The following is a description of a gene set: studied in species Mus musculus Mouse Gene Set: GOBP_POSITIVE_REGULATION_OF_PROTEIN_IMPORT_INTO_NUCLEUS Any process that activates or increases the frequency, rate or extent of movement of proteins from the cytoplasm into the nucleus., and this is the list of marker genes: Mapk14, Shh, Nutf2, Jak2, Chp2, Prkcq, Hsp90ab1, Lep, Rbm22, Gper1, Pik3r2, Xbp1, Brca1, Ifng, Zpr1 (NCBI Gene Id 22687), Mavs, Ipo5, Jup, Ubr5, Hcls1, Akap5, Mapk1, Ran, Bag3, Tpr, Dmap1, Il6, Ptpn5 (NCBI Gene Id 19259), Uaca, Nutf2-ps1, Pik3r1, Psen1, Ep300, Ect2, Tardbp, Hdac3, Ptgs2, Tek, Cdh1, Cdk1, Trim28, Ptpn22 (NCBI Gene Id 19260), Hsp90aa1, Zic1, Tgfb1, Prkd1, Tnfrsf1a, Hyal2, Zc3h12a, Smo, Gli3, Efcab7, Prkcd, Flna